Given this list of marker genes LMNA, ERCC2, RNF113A, CARS1, MPLKIP, TARS1, GTF2H5, POLD1, AARS1, RAD50, WNT10A, ERCC3, WRN, GTF2E2, NHEJ1, XRCC4, ZMPSTE24, LIG4 (DNA ligase 4), here is a description of the gene set: Human Gene Set: HP_BIRD_LIKE_FACIES studied in species Homo sapiens Bird-like facies